The following is a description of a gene set: mTORC1-mediated signalling studied in species Homo sapiens Human Gene Set: REACTOME_MTORC1_MEDIATED_SIGNALLING, and this is the list of marker genes: RPS6KB1, RRAGA, EIF4EBP1, RPS6, RRAGC, RHEB, MTOR, RRAGB, RRAGD, AKT1S1, EIF4B, MLST8, LAMTOR3, EIF4E, LAMTOR2, LAMTOR5, FKBP1A, LAMTOR1, LAMTOR4, EEF2K, EIF4G1, RPTOR, YWHAB, SLC38A9